Given this list of marker genes Fgf7, Bmp4, Nupr1, Msh4, Nr5a1, Lhx9, Lep, Eif2b2, Tiparp, Lhcgr, Schip1, Pde4d, Nppc, Dmc1, Casp3, Foxc1, Scaper, Bax, Slit3, Foxl2, Sod1, Idh1, Agt (angiotensinogen), Dach1, Lhfpl2, Esr1, Mmp19, Dach2, Inhba, Pla2g4a, Pgr, Spo11, Cyp19a1, Sirt1, Wt1, Brca2, Nrip1, Notch1, Gas2, Mmp2, Wnt4, Sprr2d, Pdgfra, Csmd1, Fst, Gpr149, Casp2, Bcas2, Nr2f2, Bmpr1b, Afp, Eif2b5, Grk2, Zfx, Lhx8, Nup107, Adamts1, Rac1, Kdr, Kmt2b, Hnrnpk, Phb1, Sfrp1, Gdf9, Dmrta1, Ctnna1, Sgpl1 (sphingosine phosphate lyase 1), A2m, Amh (anti-Mullerian hormone), Lhb (NCBI Gene Id 269911), Amhr2, Insr, Kit (NCBI Gene Id 16590), Runx1, Vgf, Lfng, Taf4, Fancf, Kitl, Bcl2l1, Fzd4, Fancg, Adrm1, Pitx2, Ube3a, Edn2, Fance, Bcl2, Ptger4, Arrb1, Sohlh1, Nobox, Immp2l, Vegfa, Hyal3, Tnfaip6, Mmp14, Retn, Ptprn, Foxo3, Zfpm2, Ubb, Arrb2, Atm, Zfp830, Myh9, Nr5a2, Ccdc182, Arid5b, Umodl1, Plekha1, Ahr, Serpine1, Lsm14b, Ptx3, Nos2, Src (Rous sarcoma oncogene), Adcyap1, Nos3, Ermp1, Stat5a, Inha, Fanca, Oas1d, Pcyt1b, Nefh, Zp3, 2610005L07Rik, Eif2b4, Ereg, Esr2, Fshb, Angpt1, Smad4, Mfn2, Inhbb, Stat5b, Npr2, Gnrh1, Fshr, Sohlh2, Cebpb, here is a description of the gene set: species: Mus musculus Mouse Gene Set: GOBP_DEVELOPMENT_OF_PRIMARY_FEMALE_SEXUAL_CHARACTERISTICS The process whose specific outcome is the progression of the primary female sexual characteristics over time, from their formation to the mature structure. The primary female sexual characteristics are the ovaries, and they develop in response to sex hormone secretion.